Given this list of marker genes KLHL42, CTSV, SNX25, NSDHL, SPNS3, ABCC4, KAT14, EIF4E, PPARGC1B, STT3B, LANCL2, TCF23, HMMR, APPBP2, EXOC6, INSR, ERI1, PRKAR2B (NCBI Gene Id 5577), RIMOC1, SLC35A3, ENSG00000285566, SCN4B, ANKRD49, CMA1, EXOSC1, ORC6, PLEKHG3, ZNF280C, CTDSPL2, SQLE, CASD1, FZD7, ZNF292, MDH1, C5orf22, SEPTIN3, ORC5, TMEM25, PPP2R5C, MACROD2, CHRNB1, MOGAT2, HOOK1, SLC7A6, C3orf62, BCL10, SUSD6, PRDX3, ENTPD7 (ectonucleoside triphosphate diphosphohydrolase 7), IL5RA, SYCP1, KCNG2, NECAP1, ABCB7 (ATP binding cassette subfamily B member 7), CYB5D2, TADA2A, OGFOD1, ZWINT, KLHL23, PPCDC (phosphopantothenoylcysteine decarboxylase), IL17RD, TNFAIP8L1, CD38, FCGR2B, RPS6KA6, SENP6, TMEM44, RABGGTA, NUS1, PAIP2, GNG10, NCAM1, SPRING1, FAM114A1, CACNG3, BRSK1, DAAM1 (NCBI Gene Id 23002), VMAC, TM7SF3, SLC10A7, KCNK15, PABPC4, PPP1R21, BSG, SOCS5, RNF38, SLC22A15, C5orf34, GOLM1, TRIM37, TPGS2, XXYLT1, PPIF, MORN1, PHF14, DLAT, MMGT1, FCRLA, ERRFI1, NTPCR, KLHDC2, ARHGAP29, PFKM, OPA1, DDX46, DOCK7, PHTF2, ORC3, NUP160, CD164, SPATA9, GNAS, NAA10, SMAD7, NSUN5, FAM78A, RPRD1A, NOP2, TCP11L2, RETREG1, ZFYVE21, GCFC2, C14orf180, GPAM, PRMT5, CHD9, HNRNPA0, NARS2, LAIR1, L2HGDH, INTS6L, ATOSA (NCBI Gene Id 56204), SESTD1, MOAP1, VBP1, TTL, AJUBA, FASTKD3, EEF1E1, FAR1, TMX4, PARPBP, GPR89B, TWSG1, PRCP, NOMO1, TTC39A, TMEM208, TMEM74B, AKR1D1, SLC35E2B, CCAR1, PRKCI, C10orf88, KBTBD7, ATP11C, GPN3, PCGF6 (polycomb group ring finger 6), UBR1, TRMT11, DLG1, ADAM9, PDE1C, NIT1, OTUD6B, SPRY4, ELP5, SMURF2, PAK1IP1, FARP2, RAB14, CD2AP, MTHFD1, GNL2, MTMR1, POLE2, GYS1, STC2, RPS6 (NCBI Gene Id 92956), TMEM50B, PAPSS1, EXOG, ANKRD46 (NCBI Gene Id 157567), STARD3NL, OSBPL1A, HCCS, BRAF, UGDH, C3orf70, DUSP14, ATP6AP1, ARFGEF2, STRA6, MARCHF6, ZNF398, PDIK1L, MST1R, MTA3, KRTAP17-1, GALNT4, here is a description of the gene set: from publication Kaji T, Ishige A, Hikida M, Taka J, Hijikata A, Kubo M, Nagashima T, Takahashi Y, Kurosaki T, Okada M, Ohara O, Rajewsky K, Takemori T (PMID 23027924) Genes down-regulated in follicular B cells versus day 7 memory B cells. To obtain insight into the genetic basis of the increase of functional activity of memory B cells over time, we compared the gene expression profiles of day 7 and day 40 NP-specific/IgG1 memory B cells, GC B cells and plasma cells in immunized WT mice and naïve B cells, before and after activation in vitro. studied in species Homo sapiens Human Gene Set: GSE11961_FOLLICULAR_BCELL_VS_MEMORY_BCELL_DAY7_DN